Given this list of marker genes Drd1, Drd4, Th, Drd5, Slc6a3, Gpr143, Drd2, here is a description of the gene set: studied in species Mus musculus Mouse Gene Set: GOMF_DOPAMINE_BINDING Binding to dopamine, a catecholamine neurotransmitter formed by aromatic-L-amino-acid decarboxylase from 3,4-dihydroxy-L-phenylalanine.